Given this list of marker genes PLEKHH1, GRSF1, SMAD5, DAPK1, LNPK, UBN1, CYB5A, NME4, SPTLC2, CARNMT1, CHP1, FNBP1, RSRC2, PCDHAC2, GPT2, GID8, CLMP, ESYT2, CNKSR3, PRRX1, SGMS1, KAT7, TJP2, SRSF6, FLOT2, KMT2A, ASCC2, MYO10, DCAF5, GBGT1, FAM234A, SUMF1, RFX4, KIF16B (NCBI Gene Id 79757), SERTAD2, CHODL, EVI5, EDNRB (endothelin receptor type B), CAMTA1, HIVEP1, GYS1, CHRD, WDR81, HIVEP2, TP53INP1, NACC1, ATP1A1, E2F3, KIF2A, UBXN1, PGAP1, RASGEF1A, UBE3A, ERN1, VPS37C, WIPF1, RAB11FIP5, TSKU, FAM53B, ZSCAN22, TRAPPC10, LRRC1, NAP1L5, TLE4, SOCS5, RHOU, KCNK10, VAMP7, FSD1L, IL17RC, SLC29A1, PCDHAC1, OAF (out at first homolog), MTR, NRAS, CHSY1, HDAC4, CDC14B, RHOG, RBM12, SLC12A2 (solute carrier family 12 member 2, NCBI Gene Id 6558), HS1BP3, UBE2O, ATP7A (ATPase copper transporting alpha), ROR2, PI4K2B, PCDHA3, MYADML, PCDHA6, BCKDHA, PLAG1, YEATS2, INTS15, USP47, FAM171A1, DENND6A, SMARCAD1, SHC1, SLITRK5 (NCBI Gene Id 26050), PTPN9, PCDHA5, PCDHA1, CAPN1, CTDSPL, RBM33, AGPAT5, ARMC1, IGF2BP1, ZFAND3, RBM24, MIDEAS, SP1, ARHGEF37, YME1L1, LRRFIP2, XPO4, ICE2, WDR44, SKI, NCK2, CPD, SLC7A1, PCDHA4, SMCO4, SERP1, SRGAP3, NIBAN2, ZMPSTE24, TBX19, SEPTIN9, DDX6 (NCBI Gene Id 1656), KPNA4, FLRT3, MYLK, BCL11B, CTDSP1, LMF2, PCDHA2, RAB11FIP1, ADNP2, RNF128, NHLH1, LMO4, CACUL1, PTBP3, LRRC57, TRABD, LZTS1, CRAT, USP6, GNG10, AK2, DNM2, PTPN12, BCAT1, RAB34, PCGF2, SLC22A5, IQGAP1, MANBAL, RFFL, MOCS1, FLOT1, VPS4B, TRAM2, MIB1, GRID1, SLC25A1, SLC2A13, MYLK2, PARP16, ATP2B4, PRKD1, C2orf69, SFT2D2, OVOL1, USP1, LIMD2, JAG1, RALGDS, FMR1, FBXO38, GATA6, STK38, ARK2C (NCBI Gene Id 494470), TFRC, ATF7IP, NSMAF, RAB3D, RYR3, SLITRK4, VCF1, NAV1, SLC15A4, CBX2, STX2, ST8SIA4, RFX1, FAM133B, AP1G1, CDH9, PCDHA10, ABHD4, RPS6KA4, GDAP2, SPIRE1, KIAA1958, THAP2, FAM210A, ITGA7, SGCZ, ARFIP1, SDF2L1, MYH10, SNTA1, PLCXD3, TLN1, SLCO5A1, SCN2B, SMPD3, CPEB1 (cytoplasmic polyadenylation element binding protein 1), PLSCR3, PLCB1, KIF3A, LUC7L2 (NCBI Gene Id 51631), ACTN4, CCND2 (NCBI Gene Id 894), FAM76B, BRWD1, RALGAPB, GALNT10, STK35, SORCS1, ZDHHC2, FAF2, TMEM117, HADH, SLC12A5, NXN, EYA1, SLC25A39, PCYOX1, ZBTB6, FAM174A, PCDHA11, CCDC71L (NCBI Gene Id 168455), STARD7, FRAS1, PAM, TMED1, SESTD1, STK4, TMEM259, TSEN54, DNAJC25-GNG10, ARID5B, NR4A3, EDEM1, BLOC1S6, E2F5, USP32, FZD4, SERINC2, SCUBE3, PLEC, SLC44A2, OGFOD3, TAMALIN, CC2D1B, FAR1, XPO5, FAM117A, FAM177A1, EYA4, PDE4B (phosphodiesterase 4B), CADM1, ANKRD27, NIPA1, MYRF, LCOR, RAB22A, DMRT1, TMEM150A, OSBP, SH3KBP1, KIF21B, PCDHA8, EFNB1, AMOT, USP32P2, G3BP1, HDAC9 (NCBI Gene Id 9734), CMPK1, BICD2, GMFB, TFAP4 (transcription factor AP-4), MARF1, ALDH9A1, GPATCH8, ABCD1, MLEC (NCBI Gene Id 9761), WIPF2, MYH9, NR2C2, EPHA2, SREK1, LRIG1, AHR, FBXO27, TFEB, WTAP, CLIP3, EIF3B, PTPRZ1, PAPSS2, SGPP1, RREB1, TNRC6B, SLC10A7, COL4A1, ACADVL, NPAT, P4HA1, GDAP1L1, ABCC4, SCD, PABIR2, TOM1L1, STK26, LINC00661, MAML1, CTNND1, BTG2, RAB10, USP38, G3BP2, PTBP1, ARHGEF6, TPD52L2, AMMECR1, FOXQ1 (NCBI Gene Id 94234), TECPR2, OSBPL10, TSC22D4, DIPK2A, CD151, MAGT1, PIK3IP1, GPAM, PSKH1, C9orf72 (C9orf72, member of C9orf72-SMCR8 complex), CHIC2, IL9R, RALBP1, CLIC6, RASSF5, GNAI1, CASQ2, SGPL1, MXD4, PHF6, PAQR9, RETREG1, CCDC177, STYX, SHC4, SHANK2, RNF114, NSUN2, SPTLC1, CCDC86, MDGA2, SEMA6D (NCBI Gene Id 80031), PAFAH1B1, RPS6KA1, CMTM4, SP7 (Sp7 transcription factor), SCN4B, SLITRK2, BACH2, NFAT5, SPINDOC, TAL1, SDC4, FMNL2, NMT1, AR, IFT56, SOX8 (NCBI Gene Id 30812), ZNF2, RCAN1, FCHSD2, ITSN2, PALLD, PIP4K2C, SRPK3, UBR7, AKT1S1, HIC1, ZNF213, PTTG1IP, SPECC1L, FAM81A, NDST1, DLX5, SLC17A5, VEZF1, PCDHA7, TSHZ1 (NCBI Gene Id 791257), LEMD3, RYR2, ST8SIA2, GNAI3, YJU2B, PRDM13, ZKSCAN3, PHF19, MYO1E, RAVER1, TMED10, TGFBR1, ABHD5, NUMA1, PCDHA12 (protocadherin alpha 12), MOB1B, TWSG1, OVOL2, TMEM104, SBNO2, STK39, SEPTIN10, KCNK2, PCDHA9, KIAA2013, TRIM39, DNAJB14, FSTL3, TMCO3, PIM1, MAPKAPK2, DDX3Y, EAF1, SGK1, BCL2L11, TBC1D1, RAD17, GRIA2, ZNF219, VCAN, GGA2, PDE5A, SYPL1, RCC2, HADHA, TPST2, NKRF, TEX261, THUMPD1, UHRF1 (NCBI Gene Id 96185), HIP1, JAKMIP3, MAP2K4, KANK1, OSBPL8, PCDH8, DLG5, GNAI2, SLIT1, EFNB3, PGF, MAPK7, ITM2C, NRP2, PDIK1L, SLITRK3, TTL, PNPLA2, SPOCK2, ARL5B, LAMC1, QKI, DACT1, LRCH4, LIMCH1, PRR3, JAG2, DLX3, CTXN1, ZNF189, CERS2, NCOA4, HIVEP3, PTPN11, PPM1F, SLC9A9, IRF1, NFATC1, TEAD1, RAB11FIP4 (RAB11 family interacting protein 4), SMOX (NCBI Gene Id 54498), EMC10, PCDH9, WSB1, DGAT2, CBL, CLDND1, TFCP2L1, HECTD2, SFRP5 (secreted frizzled related protein 5), POGLUT1, CTDSP2, IRF2BPL, NEGR1, FXR2, VAMP3, HIPK1, SPRED1, SIK2, PCDH19, DLX2, GRB2, SLC27A1, MYRIP, TP53INP2, HTATIP2, MAT2A, NR4A1, MYADM, NRP1, XRN1, TMOD1, RDH10, CD164, TMEM184B, TOR3A, LHX2, OSBPL11, MINAR1, TMEM109, SLITRK6, ITGA3, TMEM245, MGAT4A, STEAP3, CLOCK, PNKD, RNF135, ATL3, NRCAM, ZBED4, CALU, GAPVD1, YTHDF3, DUSP15, RAPH1, SLC9A2, SH3RF1, DPY19L3, ZBTB11, KLHL24, BTBD7, PGRMC2, PGM1 (NCBI Gene Id 5236), CALCOCO1, TNFSF11, RILPL1, PDCD6, UBAP2, KCTD5, GALNT9, TLE5, TRIB3, VAT1, CGN, SH2B3, ANTXR2, SNF8, PITPNA, RARG, COL5A1, SUCO, ZRANB2, DDX3X, SFMBT2, NUDCD2, SLC16A1, VAMP4, QSOX1, ADCY9, NEBL, PABIR1, N4BP1, ORC2, CEBPA, GRIN3A, AGO1, SPPL2A, DNAJC1, INSM1, CDH2, TDG, IQGAP2, CREBRF, AIF1L, ALKAL2, NR3C2, GABPB2, ADGRL1, LMO3, SEMA6A, WDR48, ENAH, RNF141 (ring finger protein 141), PHLDB1, DHCR24, VPS35, ZFP36L1, P4HA2, MID1IP1, LCLAT1, ASF1A, ITGB1, AKAP6, ANKS1B, CNEP1R1, WDFY3, AMMECR1L, FAM76A, TYSND1, WIPI2 (WD repeat domain, phosphoinositide interacting 2), APBA3, B4GALT1, RAB38, STAT3, FURIN, ZNF25, TSC22D1, SHROOM4, SLC30A7, TOMM34, DNASE2, ANXA11, GFPT2, MDK, OSBPL7, UBE4A, APLN, PRPF38B (pre-mRNA processing factor 38B), ALG2, NR3C1, PLXNA3, ZNF687, PAX3, PRDM2, PLOD3, CACFD1, GRIA3, MARVELD1, PPP1R3D, KPNA3, SCAMP2, VPS37B, EYA2, CASKIN1, MITF, CAPN6 (calpain 6), LDLRAP1, SVIL, LEMD2, ZCCHC24, CAV1, UPF3B, EPS8, EDRF1, NKAP, SLF2, SSH2, VIM, MKX, TMEM63C, ARRDC1, FCHO2, CEP43, AFF4, ADAM19, TPCN2, PLP2, PCDHA13, UBE2G1, LPP, ABCA1, SIX4, EGR2, TLCD3A, ARFGEF3, NAP1L3, BCL11A, RUFY1, NFIX, PPIF, RBL1, PAN3, NAA15, FSTL5, RXRA, PRPS1, MAPK14, SPOPL, SERTAD4, MCU, RYR1, SLC35A4, FAM174B, SH3PXD2A, GLCE, ARHGEF40, PSEN1, ZNF609, DLL4, ELK3, BCL6 (BCL6 transcription repressor), RB1CC1 (NCBI Gene Id 9821), PTBP2, RANBP10, KLF13 (NCBI Gene Id 51621), TMEM134, ADAMTS9, AXIN1, here is a description of the gene set: Genes having at least one occurence of the motif GTGCCTT in their 3' untranslated region. The motif represents putative target (that is, seed match) of human mature miRNA hsa-miR-506 (v7.1 miRBase). Human Gene Set: GTGCCTT_MIR506 studied in species Homo sapiens